The following is a description of a gene set: Human Gene Set: GSE27786_CD8_TCELL_VS_NKTCELL_UP from publication Konuma T, Nakamura S, Miyagi S, Negishi M, Chiba T, Oguro H, Yuan J, Mochizuki-Kashio M, Ichikawa H, Miyoshi H, Vidal M, Iwama A (PMID 21540074) Each fraction of mouse hematopoietic cells was purified by cell sorting from bone marrow of 8-week-old C57BL/6 mice, and its gene expression was analyzed. species: Homo sapiens Genes up-regulated in comparison of CD8 T cells versus NKT cells., and this is the list of marker genes: PHF7, ZYG11A, KCNN4, PIAS2, USP10, TPBG, GATAD2B, GDF2, LTA, DCTN4, TSPAN31, HM13, SLC66A2, SLC5A12, PIGF, NUP43, MON1A, CD6, YTHDC1, IFT25, EMB, DPYSL2, RGS19, MRPL38, LANCL1, TAF13, DBR1, NME7, SETD2, ABCA3, LRRN1, FAM241A, CARMIL2, PTCHD4, ARK2C, TTR, MBD3, ITGAE, RRN3, SMAP2, SFRP2, HADH, RYK, FAM13B, PDE1A, NHP2, MAB21L2, OLIG3, DPH5, GOLGA3, RPL4, MRPL58, ARID4A, MTG1, TMEM121, RRAS, NFS1, PNPT1, AVPI1, CLINT1, CWC15, PNPO, NBR1, ZFAT, SLC25A4 (NCBI Gene Id 7872), APRT, GSTT2, THOC7, PRR18, NOSTRIN, EIF3E, SLC35G1, NUDT6, BCAR1, LYPD6B, RYR3, CEP135, TWF2, GPRASP3, EHD1, SRSF7, SETX, USE1, LRRC23, SYCE3, COX20, EIF1, PGAP3, STK38 (NCBI Gene Id 11329), DOLK, ACVR1, ITK, GPR146, TECRL, DNAJC15, PIGA, DNASE1L2, ABRAXAS1, TMEM186 (NCBI Gene Id 25880), NPC2, CTNNBL1, CCDC28B, PELI1, ZNF131, SLC26A6, ALDOB, PPCDC, ACSS1, SMC4 (NCBI Gene Id 10593), TTC13, GCK, TBC1D15, RPL24, PDK1, MBD2, ANKRD10, EXOC3L4, TIMM21, DIPK1A, CATSPER2, FBRS, LIN9, ADCY4, MED6, PES1, RARA, PDILT, SLC6A19, CEP83, MEN1, DDA1, EEF1AKMT1, SGK3, CYSRT1, STAT5B, MRPL24, PLCXD2, EPHX1, SMCHD1, NHEJ1, TDRP, EIF4G2, ASIC3, DDO, TBC1D24, ABCC5, RGCC, MEX3B, PLCG1, NIP7, ACTN2, AVEN, CYP46A1, STK35, ATP1B3, USP28, ARHGAP15, CDC7, BICDL1, KMT2E, TMC7, TMEM11, FRYL, ASH1L, DBI, GJD2, KDM1B, TMEM130, EEF1G, CPA5, IL9R, MRPL23, STX1A, CCDC86, UTP18, ZNF446, TMEM100, TGFBR2, ARL3, CALCRL, C1QBP, PRODH2, OTUD5, SBSPON, FOXK1, CTPS1, DMBX1, MATK, OXSM, SNHG6, MRM1, MTSS1, SNX27, SH2D4B, SLAMF6, SMIM14, MSGN1, HSPBP1, MRRF, IFRD1